The following is a description of a gene set: Human Gene Set: GSE1460_CD4_THYMOCYTE_VS_NAIVE_CD4_TCELL_ADULT_BLOOD_UP species: Homo sapiens Genes up-regulated in comparison of CD4 thymocytes versus naive CD4 T cells from adult blood. from publication Lee MS, Hanspers K, Barker CS, Korn AP, McCune JM (PMID 15210650) Subpopulations of human fetal thymocyte and circulating naïve T cells were obtained through FACS sorting, including CD3-CD4+CD8- intrathymic T progenitor cells (ITTP), CD3intCD4+CD8+ \double positive\ thymocytes (DP), CD3highCD4+CD8- \single positive\ thymocytes (SP4), CD3+CD4+CD8-CD45RA+CD62L+ naive T cells from cord blood (CB4+), and CD3+CD4+CD8-CD45RA+CD62L+ naive T cells from adult blood (AB4+)., and this is the list of marker genes: SLC43A3, MSH2, CHEK2, JUN, CD38, NDNF, ZNF112, TUSC3, SALL2, PDIA4, HNRNPA1, QPCT, G3BP2, PCCB, TNFAIP3, PDGFA, SGK1, ZNF135, CCNG2, OPN3, YWHAQ, CD1D, DNMBP, BTBD3, IDH2 (isocitrate dehydrogenase (NADP(+)) 2), H2BC12 (H2B clustered histone 12), HTATSF1, KDM5B (lysine demethylase 5B), VAPA, MMD, VAV3, GATA3, MEST, STAG3, CD1E, ACVR1B, MCTP1, ETNK1, CALML4, DCLRE1A, ITGAE, FNBP1L, NEIL3, GGCX, GUCY1B1, ARHGEF7, CORO1C, SPCS3 (signal peptidase complex subunit 3), SMAD1, ALG8, ZFTA, RGS1, TTC33, IFI44L, IMMT, ZNF22, MYL6B, EXOG, APMAP, PDCD4, SCRN1 (NCBI Gene Id 9805), DCP2, JADE3, PLSCR1, MAPK14, ECHDC1, KPNB1, HDGF, MAPRE1, TPM4, DAPK1, H3C10, COPB2, R3HDM1, SPON1, RAB8B, ZMPSTE24, ETF1, VGLL4, PPP4R1, LDHA, SIL1 (NCBI Gene Id 64374), SCN3A, PTCH1, RAD23B (NCBI Gene Id 5887), CMTM6, CD93, RPRD1A, ID3, TTF2, H2BC5, BCL11A, BIRC2, DHRS3 (dehydrogenase/reductase 3), KCNMB4, STMN1, PLXND1 (plexin D1), ABCB1, PTPRK, ZNF512B, SPRY2, ACTR1A, EPAS1, CKAP2, MACIR, SRF, CCR9, FOCAD, MICAL2, INTS9, DUSP2, VIPR2, PLCH1, LZTFL1, TRAF3, SEPTIN11, ASRGL1, PHC1, SSX2IP, NR4A3, TENM1, PKIA, COTL1, ATP6V0E2, PGRMC1, SERBP1, PGK1, HTR2B, POLE3, CCRL2, CBFB, BMP2K, ENC1, GLMN, UBA5, CD200, HSPA5, FAF1, H2BC12L, FHL2 (NCBI Gene Id 2274), ARHGAP32, PPP2R1B (protein phosphatase 2 scaffold subunit Abeta), TBC1D8, VAV1, ATXN10, RSAD2, RAC2, FIG4, SMAP1 (small ArfGAP 1), HBEGF, ZSWIM8, DYNC1I2, LRRC1, TIMELESS, DNAJA1, RIMS3, USP18, CTSL, EGR1, MYH10, GSTA4, SLFN12, IARS2, CBX3, ABCD3, NDUFS6, CAPRIN1, COL6A3, TMEM248, AP1G1, TP53BP1, INTS7, STRAP, NAB1, MLLT11, CHI3L2, CRELD2, KLF10, MR1 (NCBI Gene Id 3140), HMGB1, TAF1B, CPSF6, CD3G (NCBI Gene Id 917), PLPP3, PTPN12, CHST15, WDR1, ITM2A, CASP3, ACTG1, HDAC2, MARCKSL1, ERMP1, NDFIP1, SOX4, HPGD, ROBO1, RNASE6, FCGBP